The following is a description of a gene set: Genes predicted to be targets of miRBase v22 microRNA mmu_miR_1193_3p in miRDB v6.0 with MirTarget v4 prediction scores > 80 (high confidence targets). from publication Chen Y, Wang X (PMID 31504780) studied in species Mus musculus Mouse Gene Set: MIR_1193_3P, and this is the list of marker genes: Mtf2, Ube2k, Phgdh, Gpn2, Klf4, Pofut1, Nfe2l1, Cd72, 4930523C07Rik, 2310057M21Rik, Stk32b, Dennd5b, Kng2, Ctso, Mfsd6, Plpp7, Espl1, Cask, Aktip, Scoc, Serpini1, Tenm3, Bub1, Pla2g15, Sema4f, Tmsb15l, Adamts13, Dct, Olfm1, BC048679, Hapstr1, Prkacb, Arl8b, Bach2, Tmsb15b2, Ybx3, Nhlh2, Ptbp1, Ankmy1, Tfcp2l1, Eefsec, Smarce1, Rnf181, Sla, Sim2, Fbxo28, Gata2, Serpina7, Efna5, Edem3, Khdrbs2, Lin7c, Nr1d2, Oit3, Dcun1d3, Slc16a5, Ttc39c, Ankrd17, Cacna2d1, Rabif, Zfp706, Cd200, Pim3, Grem1, Hnrnpll, Purb, Ube2w, Gm12888, Kng1, Nln, Klhl4, Ndufs4, Alg9, Hip1, Gpd1, Otop3, Ctsc, Pnpla6, Zmat3, Luc7l3, Podn, Baiap3, Stx8, Atp6v1d, Tnrc6a, Taf9b